Given this list of marker genes Ramp3, Gcg, Rab13, Tcim, Mif, Calcr, Lcp1, Iapp, Ttn, Adipoq, Tcp11, Drd4, Ezr, Mroh2b, Fbn1, Nrxn1, Fshr, Adissp, Adrb2, Akap12, Tcp11x2, Pja2, Gal, Akap5, App, Akap7, Akap6, Myom1, Rdx, Aip, here is a description of the gene set: An intracellular signaling cassette that starts with the activation of protein kinase A (PKA), and ends with the regulation of a downstream cellular process, e.g. transcription. The PKA catalytic subunit (PKA-C) is normally present in a complex with its regulatory subunit, PKA-R. The inhibitory action of PKA-R is released upon cAMP binding, which results in the activation of PKA-C. Mouse Gene Set: GOBP_PROTEIN_KINASE_A_SIGNALING species: Mus musculus